The following is a description of a gene set: studied in species Homo sapiens Human Gene Set: GOBP_NEGATIVE_REGULATION_OF_MRNA_METABOLIC_PROCESS Any process that stops, prevents or reduces the frequency, rate or extent of mRNA metabolic process., and this is the list of marker genes: DHX34 (DExH-box helicase 34), MAPK14, SRSF10, DAZ1, ZFP36 (NCBI Gene Id 7538), PTBP1, DAZ3 (deleted in azoospermia 3), UPF3A, EIF4ENIF1, TENT5C, TENT4A, RNPS1, TARDBP, CELF4, NBAS, RBM47 (RNA binding motif protein 47), C1QBP, IREB2, NICOL1, ELAVL1, RBM46, AXIN2, YBX3, SLC11A1, HNRNPA0, YBX1, DAZ2, METTL16, MAPKAPK2, TRAF3IP2, RBM24, ELAVL4, NRDE2, THRAP3, SRSF9, TRAF5, TENT5B, SRSF6, DAZ4, RBM38, HNRNPK, TIRAP, LARP4B, MEIOC, ANGEL2, NPM1, A1CF, TENT5D, ARID5A, FAM76B, ACIN1, DHX9, HNRNPAB, SYNCRIP, VIP, HNRNPU, SRSF1, HNRNPD, RBMX, CIRBP, DAZL, SAP18, QKI (QKI, KH domain containing RNA binding), ZC3H14 (NCBI Gene Id 79882), BARD1, SRSF12, SRSF4, TENT5A, SFSWAP, FUS, PKP1, IGF2BP2, PCBP4, PAIP1, LARP1B, PKP3, ZAR1, HNRNPC, TRAF2, LARP1, RBM10, IGF2BP3, IGF2BP1, NOCT, SECISBP2, DND1, SRSF7, RBM20, E2F1, BOLL, APOBEC1, TENT4B, METTL14, PABPC1, FXR1, TAF15, DYRK1A, FBLL1 (fibrillarin like 1), CSDE1, GDNF, MYD88, U2AF2, IKBKE, RBM42, TOB1, BAG4